The following is a description of a gene set: Metals to NFKB signaling pathway. Pathway ID: N01411. Pathway type: Env factor. Pathway class: nt06223 TNF signaling. Human Gene Set: KEGG_MEDICUS_ENV_FACTOR_METALS_TO_NFKB_SIGNALING_PATHWAY studied in species Homo sapiens Pathway Definition from KEGG: Metals -> ROS -| PTP -| SRC -> ABL -> PKD -> IKK -> NFKBIA -> NFKB, and this is the list of marker genes: PRKD3 (protein kinase D3), PRKD2, NFKBIA, ACP1, IKBKB, ABL2, IKBKG, PTPRJ, PTPN11, PRKD1, CHUK, SRC (SRC proto-oncogene, non-receptor tyrosine kinase), RELA, NFKB1, ABL1